Given this list of marker genes Haus5, Ecel1, 9930022D16Rik, Kcna6, Kcnj2, here is a description of the gene set: from publication Yevshin I, Sharipov R, Kolmykov S, Kondrakhin Y, Kolpakov F (PMID 30445619) studied in species Mus musculus Mouse Gene Set: ATAD2_TARGET_GENES Genes containing one or more binding sites for (Atad2) in their promoter regions (TSS -1000,+100 bp) as identified by GTRD version 20.06 ChIP-seq harmonization.